The following is a description of a gene set: Mouse Gene Set: MIR_10B_3P species: Mus musculus Genes predicted to be targets of miRBase v22 microRNA mmu_miR_10b_3p in miRDB v6.0 with MirTarget v4 prediction scores > 80 (high confidence targets). from publication Chen Y, Wang X (PMID 31504780), and this is the list of marker genes: Cxxc5, Abtb3, Junb, Phf6, Gm6878